Given this list of marker genes Il9r, Il13ra1, Ctsh, Fpr2, Il27ra, Cxcr3, Osmr, Pira2, Fpr1, Csf2rb, Il20rb, Ackr2, Il12b, Ifngr1, Ccr4, Il22ra2 (interleukin 22 receptor, alpha 2), Cxcr1, Il17ra, C5ar2, Il15ra, Fcgr2b, Ccr1, Fcer1a, Ccr9, Fcmr, Klrd1, Cd74, Gfra4 (glial cell line derived neurotrophic factor family receptor alpha 4), Cxcr5, Cmklr1, Fzd4 (frizzled class receptor 4), Fcer1g, Gfra2, Ifnlr1, Gfra1, Fpr-rs4, Fcer2a, Il1r1, Il4ra, C5ar1 (complement component 5a receptor 1), Mfsd6, Il17rd, Il7r, Fcgr3, Il1rl1, Kir3dl2, Il1rapl2, Lifr, Cxcr4, Il21r, Il12rb1, Csf2ra, Ghr, Ccr8, Lilra5, Il11ra3, Fcgr4, Il11ra2, Mpl, Ebi3, Crlf2 (NCBI Gene Id 57914), Ccr3, Il11ra1, Cxcr2, H2-Eb1, Crlf1, Fpr-rs3, Il5ra, Epor, Cr1l, Ccr2, Il2ra, Ifngr2, Il2rb, Cr2, Il22ra1, Il17rb, Ackr3, Gpr75, Il1r2, Cntfr, Pirb, Pira13, Klrc2, Gpr35, Il13ra2 (interleukin 13 receptor, alpha 2), Flt3, Cxcr6, Ackr4, Il1rl2, C3ar1, Ccr1l1, Ifnar1, Klrk1, Pira12, Fcgr1, Cd44, Ms4a2, Ccr5, Fpr-rs6, Fpr-rs7, Gpr33 (G protein-coupled receptor 33), Il6st, Prlr, Il17re, Lilra6, Csf2rb2, H2-Eb2, Ccrl2, Il18rap, Il20ra, F3, Ifnar2, Klrc1, Il10rb, Gfra3, Csf3r, Gfral, Pigr, Kir3dl1, Cd4, Il17rc (interleukin 17 receptor C), Lepr, Fpr3, Il31ra, Il6ra, Ccr6, Il10ra, Xcr1, Ccr10, Il23r, Il18r1, Ccr7, Il3ra, Il12rb2, Cx3cr1, Cd160, Il2rg, Il1rap, here is a description of the gene set: Receiving a signal and transmitting it in a cell to initiate an immune response. Mouse Gene Set: GOMF_IMMUNE_RECEPTOR_ACTIVITY species: Mus musculus